Given this list of marker genes Dhrs3, Cidec, Scarb1, Lama4, Qki, Nfs1, Hipk2, Arl4a, Stat1, Pck1, Sorbs1, Taldo1, Hsd17b4, Aqp7, Ubd, Fabp5, Hipk3, Rasd1, Acox1, Acsl1, Dgat1, Cebpa, Plin4, Dbi, here is a description of the gene set: Mouse Gene Set: RUAN_RESPONSE_TO_TROGLITAZONE_UP Troglitazone (TGZ), a member of the thiazolidinedione class of anti-diabetic compounds and a peroxisome proliferator activator receptor-gamma (PPAR-gamma) agonist, restores systemic insulin sensitivity and improves the full insulin resistance syndrome in vivo. The mechanisms underlying its in vivo function are not understood. Here we investigated the potential functional interaction between PPAR-gamma and NF-kappaB in adipocytes. We show that TGZ selectively blocked tumor necrosis factor-alpha-induced and NF-kappaB-dependent repression of multiple adipocyte-specific genes and induction of growth phase and other genes. This occurs without interfering with NF-kappaB expression, activation, nuclear translocation, or DNA binding and without suppressing NF-kappaB-dependent survival signals. Notably, the expressions of some tumor necrosis factor-alpha-induced genes in adipocytes were unaffected by PPAR-gamma activation. In reporter gene assays in HeLa cells, ectopic expression of PPAR-gamma abolished induction of a NF-kappaB-responsive reporter gene by the p65 subunit (RelA) of NF-kappaB, and the inhibition was further enhanced in the presence of TGZ. Conversely, overexpression of p65 inhibited induction of a PPAR-gamma-responsive reporter gene by activated PPAR-gamma in a dose-dependent manner. The inhibitory effect was independent of the presence of NF-kappaB-binding sites in the promoter region. Other NF-kappaB family members, p50 and c-Rel as well as the S276A mutant of p65, blocked PPAR-gamma-mediated gene transcription less effectively. Thus, p65 antagonizes the transcriptional regulatory activity of PPAR-gamma in adipocytes, and PPAR-gamma activation can at least partially override the inhibitory effects of p65 on the expression of key adipocyte genes. Our data suggest that inhibition of NF-kappaB activity is a mechanism by which PPAR-gamma agonists improve insulin sensitivity in vivo and that adipocyte NF-kappaB is a potential therapeutic target for obesity-linked type 2 diabetes. from publication Ruan H, Pownall HJ, Lodish HF (PMID 12732648) Adipocyte abundant genes up-regulated in 3T3-L1 cells (fibroblasts induced to differentiate to adipocytes) in response to troglitazone. studied in species Mus musculus